The following is a description of a gene set: from publication Mikkelsen TS, Hanna J, Zhang X, Ku M, Wernig M, Schorderet P, Bernstein BE, Jaenisch R, Lander ES, Meissner A (PMID 18509334) Genes with high-CpG-density promoters (HCP) bearing the tri-methylation mark at H3K27 (H3K27me3) in MCV6 cells (embryonic fibroblasts trapped in a differentiated state). Somatic cells can be reprogrammed to a pluripotent state through the ectopic expression of defined transcription factors. Understanding the mechanism and kinetics of this transformation may shed light on the nature of developmental potency and suggest strategies with improved efficiency or safety. Here we report an integrative genomic analysis of reprogramming of mouse fibroblasts and B lymphocytes. Lineage-committed cells show a complex response to the ectopic expression involving induction of genes downstream of individual reprogramming factors. Fully reprogrammed cells show gene expression and epigenetic states that are highly similar to embryonic stem cells. In contrast, stable partially reprogrammed cell lines show reactivation of a distinctive subset of stem-cell-related genes, incomplete repression of lineage-specifying transcription factors, and DNA hypermethylation at pluripotency-related loci. These observations suggest that some cells may become trapped in partially reprogrammed states owing to incomplete repression of transcription factors, and that DNA de-methylation is an inefficient step in the transition to pluripotency. We demonstrate that RNA inhibition of transcription factors can facilitate reprogramming, and that treatment with DNA methyltransferase inhibitors can improve the overall efficiency of the reprogramming process. Human Gene Set: MIKKELSEN_MCV6_HCP_WITH_H3K27ME3 studied in species Mus musculus, and this is the list of marker genes: ABLIM3, EPHB1, LMO1, SCN8A, LYZL4, HOXD9, BHLHE23, CABP7, CACNG4, SLC6A5, DNMT3L, CYP24A1, STMN3, CLGN, FOXD3, SLC47A2, GAL, LMTK3, DRAXIN, BIK, GBX1, CAMK2B, KCNQ4, GRP, L1CAM, SHISA7, SLITRK3, SYT16, RASL12, GABRA5, CELF4, TGFBI, NEUROG1 (NCBI Gene Id 4762), PTPN5, SLC6A17, NKD2, ATP8A2, BATF3, BMP2, RSPO1, FAM83F, SCUBE1, WNT10B, LGI2, TIMP2, OXTR, NFATC1 (NCBI Gene Id 4772), ITGA2, PCDHAC2, LHFPL3, HMX1, CHAD, BMP6, SYT10, NRG3, TTC9B, CRHR1, DHH, IRF8, FEV, AFF3, PAX2, PODXL2, VGLL2, PDE1B, ABCC8, SLC35D3, CARTPT, NXPH2, FSTL4, ALOX15, PDE4DIP, DLL3, ALDH1A3, EBF4, MMP9, NELL1, SOX1-OT, KCNS2, ANK1, WSCD2 (NCBI Gene Id 9671), CHRDL2, NPTXR, ACVRL1, SLC38A3, ZBTB16, SLC6A1, NEIL2, B3GALT5, PTPRT, GRIA2, DRD5, KCNC3, CNTN2 (contactin 2), SLC6A2, TMEM178A, ASIC4, ACAN (NCBI Gene Id 404712), PTGIS, SSTR5, ZNF804A, DYSF, RAB11FIP4, AJM1, EFCC1, KLHL40, ELFN2, GRM1, SERINC2, IRF5, GRID2IP, SCNN1B, ASIC1, RRAD, WSCD1, SLIT1, C1QL1, CYP46A1, SLC34A2 (NCBI Gene Id 153010), PTH2, PROM2, BHLHA9, SHE, CACNA2D2, PGAP6, IRX4, ANKRD63, NKD1, HOXC9 (NCBI Gene Id 3225), SCN5A, CRLF1, WNT2B, JAZF1, RAX, HCRTR1, HOXD8, LTK, SFRP5, P4HA3, INSRR, KDF1, TFAP2E, KCNH1, PCNX2, CDH22, WNT7B, CACNA1G, HTR6, C1QL2, ITPKA, BCAN, RASSF4, CLDN7, FGF8, POU3F3, CACNA1D, FGF12, MATN4, TBX5, MYO16, NOG, NEFH, SCUBE2, AEBP1, PFDN4, DISP3, PTF1A (pancreas associated transcription factor 1a), ZIC1, NRXN2, HS3ST6, AIRE, IGSF21, ABCG4, NALF1, PLPPR5, FOXC2, NPHS2, CBLN1, FZD10, TCTE1, KCND3, ADCY7, FOXF1, EMILIN3, KCNQ3, QRFPR, CLMP, DSCAM (NCBI Gene Id 1826), DLGAP2, NECAB2, EPB41L3, PDE8A, SIX2 (NCBI Gene Id 10736), SLC18A2, TCERG1L, CCKBR, DRGX, GNB4, COL8A2, MYRIP, NKX2-5, APLN, SDK2, LGI3, CLSTN2, VSTM2L, JPH3 (junctophilin 3), HHIPL1, GABRD, ACHE, CHAT, RAB6B, SCRT1, SLC32A1, DBN1, HOXC10, KCNC4, PYY, SCN4B, ARX, COL15A1, TBX21, ZNF641, GABBR2, ASIC2, CHRNB2, CPNE5, ALOX12B, ELOVL3 (NCBI Gene Id 83401), SEMA7A, FIBCD1, RBP4, CCN3, MMD2, AIFM3, IRX1, GDNF, ADGRA2, LMX1A, KCNQ1, DBNDD1, CHRNA3, DOCK3, NPTX2, DPYSL4, VSTM4, PRDM13, FAM163A, RASL10B, SIM2, CORO2B (coronin 2B), MYOD1, LRTM2, SLC18A3, CCDC92B, TC2N, CACNA2D3, SLC6A7, ASCL2, KCNT1, COL9A2, HOXD12, SYT6, NKX2-3, RPRML, FAR2, NKX2-4, AFAP1L1, WDR86, DOC2B, PGF, TMEM215, MAFB, NKX3-1, IHH, HES5, KCNJ4, SLC8A2, STUM, STK32C, PSD2, GJB6, ECEL1, LAMC3, AQP5, SLIT2, NELL2, TRNP1, EPHA8, GSX2, HOXC12, COL13A1, CNNM1, FGF5, HTR7, BARX1, UNCX, CACNA1I, MYCL, ADRA2C, TP73, FAM43B, FBLL1, POU2F3, HOXD4, SHH, SEZ6L, TMEM59L, FOXE3, LMX1B, TRIM58 (tripartite motif containing 58), GRB10, RASGEF1C, SKOR1, DMRT3, LHX5, YBX2, FAM83G, SLC30A10, GATA5, KCNH6, RBFOX3, VSX2, RELN, BSN, FAM184A, PHF24, ONECUT3, KCNK15, KCNH2, KL, NKX6-2, GRIN2C, GRIP1, HBQ1 (hemoglobin subunit theta 1), SH3RF3, INSL3, GDF7, PAQR5, DPP10, EMX1, SSTR1, COMP, FOXE1, NTRK3, PTPRB, SCTR (NCBI Gene Id 6344), PRLHR, NTSR2, TMEM54, CXCL14, KRT7, CIMIP2C (NCBI Gene Id 339778), EFNA2, PANX2, CHD5, FOXB2, DOK6, PDLIM2, CCDC184, NEUROD1, ADORA2A, ADGRB2, GRIN3B, HS3ST2 (NCBI Gene Id 9956), SYNDIG1L, FGF3, EVX2, BEX1, PDX1, GLDC, ADAMTS2 (ADAM metallopeptidase with thrombospondin type 1 motif 2), BRSK2, GFRA3, RAMP1, PHYHIPL, HTR1D, ACE, MIXL1, LHX3, RSPO4, OAF, TMEM151B, ADGRB1, GRID1, SPTBN2, IL1RL2, LRRC75B, GABRA4, LBX1, SPON1, HBZ, JHY, NPAS3, FBXO41, NHLH2, RTN4R, WNT3A, KCNA2, TDRD6, DRD4, GATA4, TMEM91, NEUROG3, SYT2, SLC2A13, HOXD11, AK5, C1QL4, SKAP1, C1QTNF4, SLC7A10, ATP2B2, SLC9A3, TBXT, ATP2B3, NKX6-1, NTSR1, FEZF2, PACSIN1, FNDC5, OTOP3, PRMT8, KCNQ2 (NCBI Gene Id 3785), ADAMTS18 (ADAM metallopeptidase with thrombospondin type 1 motif 18), KCNMA1, VSX1, ALOX12, RIMS4, CCK, TMEM30B, DIO3, LAMP5, TRHDE, MYCBP2, HSD11B2, SLC35F3, TMEM132E